Given this list of marker genes Serpine2, Plg, Plaur, Serpinb8, Anxa2, Plau, Hrg, Serpinf2, Serpinb2, here is a description of the gene set: electronically inferred by orthology from the curated human pathway studied in species Mus musculus Reactome Pathway: Dissolution of Fibrin Clot part of: Hemostasis This event has been computationally inferred from an event that has been demonstrated in another species.<p>The inference is based on the homology mapping from PANTHER. Briefly, reactions for which all involved PhysicalEntities (in input, output and catalyst) have a mapped orthologue/paralogue (for complexes at least 75% of components must have a mapping) are inferred to the other species.